Given this list of marker genes Ube2a, Chia1, Srpk1, Phactr2, Klhdc10, Htr3a, Zfp609, Pax6, Rap2a (RAS related protein 2a), Pbx1, Ttbk2, Wnt2b, Scn4b, Magi1, Rora, Lalba, Surf6, Zbtb7c, Trim40, Peak1, Dynlrb2, Exd1, Dnajb4, Fbxl14, Cbx8, Abcg4, Ywhaz, Sart3, Cxcl16, Stx1b, Igf2bp3, Nova2, Cdh7, Kdm7a, AI597479, Parvb, Cstf3, St3gal2, Slc5a7, Marf1, Setd1b, Tpst2 (NCBI Gene Id 436577), Ugt2b1, Hnrnpc, Map3k9, Eda2r, Slc6a11 (solute carrier family 6 (neurotransmitter transporter, GABA), member 11), Rfx7, Tub, Epha4, Zc3h4, Mid2, Olfml2a, Arhgef9, Zdhhc5, Nudt15, Hcfc1r1, Mab21l3, Lss, Mllt11, Tmem164, Mroh6, Casp8, Tmem245, Btrc, Fbxo11 (NCBI Gene Id 98072), Ccdc157, Usp2, Samd10, Sod3, Rfng, Asb7, Slc22a23, Ppp2r2d, Morc2a, Cdc25a, Slc17a5, Ago1, Arih1, Edem1, C1qtnf1, Rraga (NCBI Gene Id 68441), Pak6, Tmem255a, Zfp174, Polh, 2310022A10Rik, Sema4c, Hycc2, Ston2, Cep250, Lrrc41, Dapl1, Spata2, Tmc2, Ocrl, Ppm1l, Olfml1, Patl1, Cyp4a31, Gdnf, Usp54 (ubiquitin specific peptidase 54), Tshr, Dcaf7, Sdc1, Nsg2, Emx1 (empty spiracles homeobox 1), Tspyl2, Pitpnm1, Crem, G6pdx, Bicral, Vamp2, Arhgap18, Dnajc19, Phlpp2, Khdc4, Gm12185, Stox2, Ogg1, Pcyt1a (phosphate cytidylyltransferase 1, choline, alpha isoform), Zfp12, Cfap141, Jph4, Ido2, Pex19, Gsk3b, Slc10a7, Eddm3b (epididymal protein 3B), Sp3, S1pr2, Stip1, Zfp444, Rab5c, Hcls1, Zdhhc8, Wasf3, Dtx3l, Rab43, Trp53inp2, Smpd3, Nherf1, Fndc5, here is a description of the gene set: Mouse Gene Set: MIR_7665_5P Genes predicted to be targets of miRBase v22 microRNA mmu_miR_7665_5p in miRDB v6.0 with MirTarget v4 prediction scores > 80 (high confidence targets). studied in species Mus musculus from publication Chen Y, Wang X (PMID 31504780)